Given this list of marker genes CD74, HLA-DRB4, HLA-DQA1, HLA-DPA1, HLA-DRB3, HLA-DPB1, HLA-DRA, HLA-DRB5, HLA-DRB1, HLA-DMA, HLA-DQB1, HLA-DMB, HLA-DOA, HLA-DQA2, HLA-DOB, here is a description of the gene set: studied in species Homo sapiens Human Gene Set: KEGG_MEDICUS_REFERENCE_ANTIGEN_PROCESSING_AND_PRESENTATION_BY_MHC_CLASS_II_MOLECULES Antigen processing and presentation by MHC class II molecules. Pathway ID: N00590. Pathway type: Reference. Pathway class: nt06168 Herpes simplex virus 1 (HSV-1). Pathway Definition from KEGG: CD74 -> MHCII